Given this list of marker genes MAB21L2 (NCBI Gene Id 10586), MTOR, SHOX, TONSL, KYNU, ALG9, GPC6, DHCR24, IFT140, MMP13, PEX7, SERPINH1, B3GAT3, FGFR3, CSPP1, PTH1R, AGPS, GPX4, EBP, FGFR1, COL11A1, WDR19, GNPAT, RMRP, ASXL1, CTSK, HDAC6, LBR, COL2A1, CEP57, WDR35, COG1, GSC, IFT80, CRTAP, DHCR7, POC1A (NCBI Gene Id 25886), DYM, ARCN1, SIK3, PRKG2, PKDCC, ACAN, IFT52, INPPL1, B3GLCT (NCBI Gene Id 145173), CHST3 (NCBI Gene Id 9469), MBTPS2, CLPB, CFAP410, KMT2A, GNPNAT1, TBX15, FGFR2, CEP120, PCYT1A, IFT122 (intraflagellar transport 122), DVL1, FLNB, MYSM1, WNT5A, CREB3L1, SLC26A2, IFT43, GDF5, KIAA0586, FZD2, ALG12, here is a description of the gene set: Disproportionate shortening of the proximal segment of limbs (i.e. the femur and humerus). Rhizomelia studied in species Homo sapiens Human Gene Set: HP_RHIZOMELIA